Given this list of marker genes PAK2, ARHGAP10, here is a description of the gene set: Reactome Pathway: Regulation of PAK-2p34 activity by PS-GAP/RHG10 part of: Regulation of Apoptosis species: Homo sapiens PS-GAP (RGH10) interacts specifically with caspase-activated PAK-2p34 reducing the ability of PAK-2p34 to induce cell death. This interaction inhibits the kinase activity of PAK-2p34 and changes the localization of PAK-2p34 from the nucleus to the perinuclear region.